Given this list of marker genes NUBP2, TF, NUBP1, FXN, COX17, CCS, PARK7, ATOX1, NUBPL, SCO2, ZNG1E, DPH3, SCO1, ISCU, ATP7A, here is a description of the gene set: Binding to and delivering metal ions to a target protein. species: Homo sapiens Human Gene Set: GOMF_METALLOCHAPERONE_ACTIVITY